The following is a description of a gene set: studied in species Homo sapiens Human Gene Set: GOBP_PROSTATIC_BUD_FORMATION The morphogenetic process in which a region of the fetal urogenital sinus epithelium is specified to become the prostate, resulting in prostate bud outgrowth., and this is the list of marker genes: WNT5A, BMP7 (bone morphogenetic protein 7), SULF1, FGF10, NOG, AR, SHH, BMP4, TP63